The following is a description of a gene set: Human Gene Set: JEON_SMAD6_TARGETS_UP Genes up-regulated in H1299 cells (lung cancer) upon knockdown of SMAD6 by RNAi. studied in species Homo sapiens from publication Jeon HS, Dracheva T, Yang SH, Meerzaman D, Fukuoka J, Shakoori A, Shilo K, Travis WD, Jen J (PMID 19047146) The malignant transformation in several types of cancer, including lung cancer, results in a loss of growth inhibition by transforming growth factor-beta (TGF-beta). Here, we show that SMAD6 expression is associated with a reduced survival in lung cancer patients. Short hairpin RNA (shRNA)-mediated knockdown of SMAD6 in lung cancer cell lines resulted in reduced cell viability and increased apoptosis as well as inhibition of cell cycle progression. However, these results were not seen in Beas2B, a normal bronchial epithelial cell line. To better understand the mechanism underlying the association of SMAD6 with poor patient survival, we used a lentivirus construct carrying shRNA for SMAD6 to knock down expression of the targeted gene. Through gene expression analysis, we observed that knockdown of SMAD6 led to the activation of TGF-beta signaling through up-regulation of plasminogen activator inhibitor-1 and phosphorylation of SMAD2/3. Furthermore, SMAD6 knockdown activated the c-Jun NH2-terminal kinase pathway and reduced phosphorylation of Rb-1, resulting in increased G0-G1 cell arrest and apoptosis in the lung cancer cell line H1299. These results jointly suggest that SMAD6 plays a critical role in supporting lung cancer cell growth and survival. Targeted inactivation of SMAD6 may provide a novel therapeutic strategy for lung cancers expressing this gene., and this is the list of marker genes: SERPINE1 (NCBI Gene Id 5054), MMP7 (NCBI Gene Id 4316), THBS1, FAS, TIMP2, PSMB8 (proteasome 20S subunit beta 8, NCBI Gene Id 5696), CXCL8, NRG1, KLRC2, TRIB1, RFTN1, DKK3, JUN, LAMC2, SERPINH1, TRIO, QSOX1, PTX3, SERINC5, TGFB2, CSF1, FBN1, UBD, FILIP1L